Given this list of marker genes MIR644A, MPDU1, GCNT7, CHST5, SOAT1, CANT1, POGLUT3, ALG1, CRPPA, MGAT2, ALG10B, OST4, POFUT2, POGLUT1, DPY19L1, COLGALT1, PSEN1, NUS1, B3GLCT, MIR153-1, GALNT13, UGGT1 (UDP-glucose glycoprotein glucosyltransferase 1), FUT4, STT3B, NDST1, POMGNT1, TET1, ALG2, AATF, XYLT2, CHST3, TMEM260, EXTL1, ST8SIA2, ALG8, EXTL3, MGAT4B, ST8SIA3, GCNT4, ABCA7, C1GALT1, ST3GAL6, GALNT17, HS3ST1, CSGALNACT1, NECAB1, DERL3, OSTC, LMF1, ST6GAL1, PMM1, GOLPH3, AQP11, CHPF, RAMP1, GCNT1, TRAK2, DPM1, TMEM165 (transmembrane protein 165), GXYLT1, B3GALT5, CWH43, POMT1, GORASP1 (NCBI Gene Id 64689), MIR455, DAD1, GAL3ST3, LARGE2, FREY1, EXT1, B3GNT8, GFPT1, CHST8, B3GALT2, GALNT14 (NCBI Gene Id 79623), DPY19L3, HS3ST3B1, NCSTN, ACER2, ALG14, ALG13, FUT5, B3GALT4, CHST10, PLOD3, B3GALT1, B4GALT1, STT3A, NECAB3, HS6ST2, B4GAT1, NECAB2, MIR323A, MAN1A1, GALNT12, ST3GAL4, ARFGEF1, HS3ST4, GALNT9, GALNT1, TMEM258, CHST6, UGGT2, FUT8, TMEM106A, ALG11, B3GNT4, UGDH, GLCE, FUT2, UBE2J1 (ubiquitin conjugating enzyme E2 J1), B4GALT4, C20orf173, DHDDS, MAN2A1, CHST4, SRD5A3, C1GALT1C1, PAWR, PLOD1, ABCA2, FUT3, COG3, MIR147A (NCBI Gene Id 406939), IGF1, NDST2, GMPPA, ALG12, ST3GAL3, GALNT6, BMPR2, GALNT5, HS3ST3A1, B4GALT6, GMPPB (NCBI Gene Id 29925), ST6GALNAC4 (NCBI Gene Id 27090), GALNTL5, B3GAT1, TMTC2, TRAK1, DSE, ST3GAL5, GXYLT2, CHPF2, GOLGA2, GALNT4, MAGT1, EXTL2, GATA1, HS3ST2, ALG1L2 (ALG1 chitobiosyldiphosphodolichol beta-mannosyltransferase like 2), EXT2 (NCBI Gene Id 2132), CHSY3, RPN1, GALNT18, CCL19, POGLUT2, TCF7L2, SLC10A7, TUSC3, ST3GAL1, MIR20A, UST, CHST7, A4GNT, ALG6, DDOST, IL33, CCL21, OGT, MAN2A2, ST3GAL2, NDST3, CCR7, ITM2B, RFT1, GALNTL6, CHST2, CHST11, ENTPD5, B4GALT2, SLC35B2, AGO2, GAL3ST4, DPM3, ST8SIA6, ST6GALNAC3, KRTCAP2, BMPR1B, MOGS, B3GNT5, ITM2C, CHSY1, ST6GALNAC5, MIR106A, MIR144, CHST14, B3GNT6, FUT1, B4GALNT2, CHST1, SLC2A10, CTNNB1, DOLPP1 (dolichyldiphosphatase 1), B3GALT6, NAGPA, TET3, FAM20B, ST6GALNAC2, ST6GALNAC1, MUSTN1, POFUT1, TMTC1, ITM2A, ATP7A, NPC1, B3GALT9, GALNT3, TRIP11, ST8SIA1, VANGL2, MIR298, MIR17 (microRNA 17), GALNT2, B3GALNT2, TMTC3, FUT6, RPN2, DPM2, XYLT1, B3GNT9, HS6ST3, B3GAT2, NUDT14, MIR31, NDST4, HS2ST1, ST6GAL2, B3GAT3, TNIP1, SERP1, DPAGT1, ALG9, ALG5, GALNT7, FKTN, RXYLT1, BACE2, GAL3ST1, SLC35D2, FUT10, B3GNT3, MAN1A2, CYTL1, PLCB1 (phospholipase C beta 1), CSGALNACT2, CHST9, EDEM3, POMK, GBGT1, CHST12, TM9SF2, ANGPT1, MGAT4A, PLOD2, HS3ST5, TMEM59, MAN1B1, MIR520C, POMGNT2, FKRP, GALNT15, MAN1C1, TET2, EOGT, LARGE1, PGM3, GALNT8, B3GNT7, CHP1, GALNT10, B4GALT7, MGAT4C, ST8SIA4, XXYLT1, SLC39A8, FUT9, ALG3, MGAT4D, MGAT5B, B3GNT2, CHST13, VEGFB, MIR101-1, OGA, JAK3 (NCBI Gene Id 3718), MGAT1, MGAT5, FOXL1, GALNT16 (polypeptide N-acetylgalactosaminyltransferase 16), FUT7, CCDC134, GAL3ST2, GALNT11, GCNT3, PMM2, ST6GALNAC6, SLC35C2, ABO, ACOT8, TMTC4, BCL2, GCNT2, B4GALT3, ALG10, POMT2, FUT11, PXYLP1, HS3ST6, HS6ST1, SLC51B, GFPT2, DOLK, ST8SIA5, B3GALNT1, MGAT3, COG7, B4GALT5, here is a description of the gene set: studied in species Homo sapiens The chemical reactions and pathways resulting in the formation of glycoproteins, a protein that contains covalently bound glycose (i.e. monosaccharide) residues; the glycose occurs most commonly as oligosaccharide or fairly small polysaccharide but occasionally as monosaccharide. Human Gene Set: GOBP_GLYCOPROTEIN_BIOSYNTHETIC_PROCESS